The following is a description of a gene set: Mouse Gene Set: GOMF_LIPID_TRANSFER_ACTIVITY Removes a lipid from a membrane or a monolayer lipid particle, transports it through the aqueous phase while protected in a hydrophobic pocket, and brings it to an acceptor membrane or lipid particle. This results in intermembrane transfer of lipids. species: Mus musculus, and this is the list of marker genes: Apoa4, Pitpnm1, Cideb, Stard5, Mttp, Bltp1, Osbpl5, Abcg1, Bltp3b, Tnfaip8l3, Abcg8, Cptp, Osbpl8, Gltp, Esyt1, Atg2a, Prelid1, Osbp, Pitpna, Gltpd2, Scp2, Ttpa, Pltp, Triap1, Star, Prelid3a, Gramd1c, Gramd1b, Pitpnb, Abca1, Pitpnm2, Apoe, Pitpnc1, Cidea, Abcg5, Stard4, Plekha8, Stard3, Apoa2, Osbpl2, C2cd2l, Apob, Prelid3b, Cidec, Abca3, Prelid2, Cert1, Npc2, Gramd1a, Atg2b, Apoa5, Npc1, Apoa1